Given this list of marker genes ATXN7L3, CEP112, MLEC, SMAP1, VPS26A, MTMR1, SEZ6, UPF1 (UPF1 RNA helicase and ATPase), TPO, COX16, TADA1, ATXN1, ZDHHC5, SMURF1, HMGA2, RFX7, PSD3, ZDHHC15, ZNF827, RNF20, FLT1, CES3, CASKIN1, TMEM117, TPCN1, ATP11A, ZCCHC17, DHX35, BAZ2A, MTCL2, DOCK4, RAPGEF1, AP3M1, FOXO1, DNMT3B, CHD2, ING3, APOBEC3F, LRRK1 (leucine rich repeat kinase 1), SEC22C, SERTAD4, SLAMF6, RAP1GDS1, IFIT1, CDC42EP4, GRIP1, NFASC, PLEKHG4B, BICD2, TMEM161B (transmembrane protein 161B), SCG3, CCDC198, EXOC7, USP37, INO80, MAU2, GSS, KLF12, CHST15 (NCBI Gene Id 9916), DCBLD1, SMAD1, ERVV-2, TRIM33, MBNL1, USP39, ADCY1, CD84, DSTYK, PRTFDC1, MGMT, PMAIP1, CHST11, NR4A3, AFF1, ADGRA2, SLC4A4, AR, PAG1, DBX2, OSCAR, GPD1 (glycerol-3-phosphate dehydrogenase 1), TPM4, CNTNAP1, OR12D3 (NCBI Gene Id 81797), PEAK1, SRSF6, ARMC7, SPTSSB, FAM193A, SYNJ2BP-COX16, WNT10B, ZNF189, HNRNPL (heterogeneous nuclear ribonucleoprotein L), here is a description of the gene set: studied in species Homo sapiens Human Gene Set: MIR370_3P from publication Chen Y, Wang X (PMID 31504780) Genes predicted to be targets of miRBase v22 microRNA hsa-miR-370-3p in miRDB v6.0 with MirTarget v4 prediction scores > 80 (high confidence targets).